The following is a description of a gene set: species: Homo sapiens Abnormality of the distal phalanx of the 2nd finger Human Gene Set: HP_ABNORMALITY_OF_THE_DISTAL_PHALANX_OF_THE_2ND_FINGER, and this is the list of marker genes: FGFR2, COL2A1, FIG4, NSDHL, BMPR1B, TWIST1